Given this list of marker genes Rfwd3, Rora, Gm12980, Eif1ad8, Yars1, Dcakd, Cbfb, Zfp809, Rps6-ps3, Gm11665, Cep95, Sec24c, Fam81a, Ube2d-ps, Usp1, Eif5a, Tsc22d4, Mrpl14, Sag, Arl2bp, Srsf1, Ppfibp2, Usp14, Btbd19, Lhfpl4, Shoc1, Myo15a, Uba52, Ddb2, Sp1, Mis18bp1, Arrdc3, Ube2i, Nfat5, Vdr (NCBI Gene Id 22337), 1700022A21Rik, Gm15651, Gm16519, S100pbp, Zbtb8a, 1700023H06Rik, Adat1, Gm12740, Ift172, Gm4349, Mlxip, here is a description of the gene set: from publication Yevshin I, Sharipov R, Kolmykov S, Kondrakhin Y, Kolpakov F (PMID 30445619) studied in species Mus musculus Mouse Gene Set: GM14393_TARGET_GENES